Given this list of marker genes GNPTAB, PLCB3 (phospholipase C beta 3), SRP54, AIFM1, EED, EXT2, GJA1, ACAN, MATN3, CCN6, WDR19, DDRGK1, COL11A1, ACVR1, ALG9, GSC, FGFR3, SBDS, EXTL3, COL10A1, ARSB, TRIP11, ARCN1, CANT1, VAC14, LIFR, B3GALT6, EFL1, SKI, DDR2, IDH1, LRP5, MAP3K7, RUNX2, B3GAT3, FLNA, PCNT, GLB1, ERCC1, B4GALT7, NANS, TCIRG1, MMP2, IDUA, FAM111A, GALNS, TRPV4, TONSL, ANKH, PRKG2, SLC39A13, HSPG2, XYLT1, PTDSS1, DNA2, SH3PXD2B, PEX7, SLC26A2, MMP13, BMPR1B, VPS33A, ACP5, KIF22, POLR1A, DNAJC21, COL11A2, IARS2, EZH2, PHEX, NPR2, COG4, COL2A1, NEK1, DYM, INPPL1, PCYT1A, CCN2, AXIN1, LBR, ATP7A, HNRNPH1, PTH1R, FIG4, NSMCE2, EXT1, CHST3, ABCC9, MMP9, CSF1R, CYP3A4, DYNC2H1, SLC35D1, CTNS, TAPT1 (transmembrane anterior posterior transformation 1), RMRP, SFRP4, OSTM1, COMP, here is a description of the gene set: Human Gene Set: HP_METAPHYSEAL_WIDENING Abnormal widening of the metaphyseal regions of long bones. Metaphyseal widening species: Homo sapiens